The following is a description of a gene set: Genes predicted to be targets of miRBase v22 microRNA mmu_miR_677_5p in miRDB v6.0 with MirTarget v4 prediction scores > 80 (high confidence targets). Mouse Gene Set: MIR_677_5P studied in species Mus musculus from publication Chen Y, Wang X (PMID 31504780), and this is the list of marker genes: Gata3, Cracd, Naaladl2, Papss2, Sema3a, Camk2d, Hoxc13, E2f5, Zfp956, Clcn5, Cblb, Sbf2, Dcx (NCBI Gene Id 13193), Cand1, Osgep, Nr1d2, Ccnf, Btbd3, Fam210a, Meox2, Zeb2, Angptl1, Ptprk (protein tyrosine phosphatase receptor type K), Dlg2, Pcdh17, Gm11541, Rgs7, Appl1, Atp7b, Grm5, Kif3b, Sohlh2, Tra2a, C1galt1, Ammecr1, Ro60, Timm8a1, Rictor, Rb1, Gpatch8, Dab1, Rps6ka3, Tbc1d23, Itgb6, Rnasel, Lsm14a, Pgap2, Adamts5, Dcaf12, Cyp3a25, Idh3b, Rph3al, Mindy2, Celf1, Il1rapl2, Camsap1, D16Ertd472e, Epha5, Rmdn1, Uspl1, Rragc, Fam3c, P2rx5, Tbx3, Orc5, Agbl4, Zfp511, Ipcef1, Orc2, Gid4, Pnpla8, Rc3h1, Cyp3a59, Epdr1, Prr23a4, Zdhhc7, Birc6, Tmprss11b, Scn9a, Tead1, Syncrip, Vmn1r45, Tmem267, Emc7, Casp7, Tnfsf8, Eogt (NCBI Gene Id 58893), Slc15a4, Gclc, Sowahc, B3gat2, Itsn2, Mllt10, Sec14l3, Gpx5, Tril, Antxr2, Prkaa1, Cyria, Nup153, Usp28, Jmy (NCBI Gene Id 57748), 1810037I17Rik, Gdpd4, Sema3b, Dcbld2, 5730507C01Rik, Phkb, 9330159F19Rik, Tnks2, Dennd2c (DENN domain containing 2C), Btbd18, Kctd9, Zfyve26, Gpr22, Pde9a, Ago2, Nlrp10, Tet2, Ppp1r14bl (NCBI Gene Id 66755), Chgb, Ctdspl2, Lama4, Scarb1, Ginm1, Tent4b, Bmp2k, Map1b, Plcb2, 9130008F23Rik, Fmr1, Rnf151, Suz12, Acbd5, Fgl2, 1700025G04Rik, Sgms2, Txndc15, Erap1, Eda2r, B4galt5, Socs6, Ambn, Vbp1, 4930447C04Rik, Bcl7b, F5, Ube2z, Adam10, Lyrm1, Ypel5, Sdc2, Clec4f (C-type lectin domain family 4, member f), Prr16, Asph, Ppm1d, Svopl, Srsf11, D5Ertd579e, Robo2, Adgrg2, Canx, Plek, Acp1, Rras2, Nap1l2 (NCBI Gene Id 17954), Clcn4